Given this list of marker genes CD151, HSD11B2, EFNB3, RBP4, ANK3, IL4R, IGSF10, ACTN2, ABCA1, PIM2, SERPINA2, ANKS3, LDAF1, SAMHD1 (SAM and HD domain containing deoxynucleoside triphosphate triphosphohydrolase 1), SPIN1, IGKV5-2, WDSUB1, GJA4, RAB4B, IGHE, IDUA, CD2, GALT, FHL1, SREBF2 (NCBI Gene Id 6721), TBXA2R, PKIB, RABEP1, BCL3, RELN, PSEN2, CYP2B6, SLC25A53, AATK, HCK, ZG16, KLK1, HSPB8, RAG1, SELENOP, WT1 (NCBI Gene Id 7490), JUN, ENDOU, LIPC, SBF2 (SET binding factor 2), DBNDD2, CAPG, UBA7, PRM1, MDN1, BAZ2A, PRRG2, POMC, CD55, BIRC3, FBP2, LSP1, SPINK1, COL4A3, KMT2B, SRF, IER3, GPR137B, EVL, NFKBIZ, CAPN1, GOT1, TRDC (T cell receptor delta constant), here is a description of the gene set: from publication Hoffmann R, Seidl T, Neeb M, Rolink A, Melchers F (PMID 11779835) Gene expression profiles of five consecutive stages of mouse B cell development were generated with high-density oligonucleotide arrays from as few as 2 x 10(4) ex vivo isolated and flow-cytometrically purified cells. Between 2.8% and 6.8% of all genes change on differentiation from one cellular stage to the next by at least twofold. The entire pathway involves differential expression of 10.7% of all genes. Previously known expression patterns of genes (like surrogate light chain, RAG-1/2, MHC class II, mel-14 antigen) are confirmed. The gene expression patterns of the proliferating pre-BI and large pre-BII cells on the one hand, and the resting immature and mature B cells on the other hand, are most similar to each other. Small pre-BII cells display a pattern that is transitional between these two groups. Most of the genes expressed in early precursors are involved in general processes, like protein folding or cell cycle regulation, whereas more mature precursors express genes involved in more specific molecular programs (cell surface receptors, secreted factors, and adhesion molecules, among others). Between 19 and genes share a given expression pattern. Combining knowledge about gene function and expression pattern allows identification of novel candidate genes potentially involved in self-maintenance of pre-BI cells, allelic exclusion and pre-B cell receptor signaling in large pre BII cells, cell-cycle arrest of small pre-BII cells, propensity toward apoptosis or anergization in immature B cells, propensity toward cell division and activation in mature B cells, and stage-specific interactions with stromal cells in the bone marrow. Human Gene Set: HOFFMANN_LARGE_TO_SMALL_PRE_BII_LYMPHOCYTE_DN species: Mus musculus Genes down-regulated during differentiation from large pre-BII to small pre-BII lymphocyte.